Given this list of marker genes MMADHC, CD320, MTRR, TAMM41, PRDX1, ACSF3, LMBRD1, MMAA (metabolism of cobalamin associated A), MCEE, SUCLG1, SFXN4, HCFC1, TCN2, MMAB, MLYCD, MMUT, MTR, MMACHC, ABCD4, SUCLA2, ALDH6A1, here is a description of the gene set: Human Gene Set: HP_METHYLMALONIC_ACIDURIA Methylmalonic aciduria species: Homo sapiens Increased concentration of methylmalonic acid in the urine.